Given this list of marker genes Drd1 (dopamine receptor D1), Drd3, Oprd1, Gnal, Oprm1, Drd5, Nherf1, Adcy5, Taar1 (trace amine-associated receptor 1), Ptger1, Gnas, here is a description of the gene set: studied in species Mus musculus An adenylate cyclase-activating G protein-coupled receptor signaling pathway initiated by dopamine binding to its receptor, and ending with the regulation of a downstream cellular process. Mouse Gene Set: GOBP_ADENYLATE_CYCLASE_ACTIVATING_DOPAMINE_RECEPTOR_SIGNALING_PATHWAY